Given this list of marker genes GLE1 (NCBI Gene Id 8012), ZC3H11A, FBL, TCP1, IGF2BP2, NUP37, IGF2BP1, NUP43, KPNB1, DHX9, ARC, AAAS, FXR1, RTRAF, YTHDC1, TPR, NSUN2, EXOSC10, DDX39A, THOC3, NUP93, NXF5, IWS1, ZNHIT3, SARNP, DKC1, EIF4A3, QKI, MEX3D, NUP50, NOL6, NUP188, A1CF, MVP, FMR1 (fragile X messenger ribonucleoprotein 1), NUP205, RAN, SMG5 (SMG5 nonsense mediated mRNA decay factor), HSF1, NXT2, FXR2, PCID2, SRSF1, ALKBH5 (alkB homolog 5, RNA demethylase), NXF1, YBX1, NUP160, HNRNPA1L2, RAE1, EIF4E, DDX19B, CCT5, SETD2, FUBP3, G3BP2 (G3BP stress granule assembly factor 2), PARN, ZFP36L1, PARP11, POM121B, C12orf50, NUP107, NUP62, MRPL18, NAF1, SUPT6H, NUP214, ZFP36 (ZFP36 ring finger protein), NUP88, THOC6, MX2, NCBP1, SLBP, KIF5C, UPF2 (NCBI Gene Id 26019), WRAP53, NPIPA1, POM121, PIH1D1, LRPPRC, PUM2, NXF2, LUZP4, NDC1, PRPF6, NUP42, CCT2, NUTF2, SHQ1, UPF3B, ATR, CETN2, SRSF3, YY1, TERF1, DDX19A, TOMM20, XPO1, CCT6A, ZC3H11B, FLOT1, CKAP5, SSB, SRSF7, NXF3, PNPT1, DDX25, NCBP3, NUP155, RUVBL1, AKAP8L, NPAP1, RBM15B, IGF2BP3, RANBP17, XPO5, DCP2, CCT8, CPSF6, ATXN2 (NCBI Gene Id 8095), POM121L2, PRPF31, THOC7, NRDE2, ENY2, ZNHIT6, HNRNPU, SEH1L, NXF2B, NOP58, THOC2, MCM3AP (minichromosome maintenance complex component 3 associated protein), NCBP2, RANBP2, RFTN2, PHAX, ZC3H11C, NUP35, SEM1, HNRNPA1, NUP133, RBFOX1, AGFG1, KHSRP, SIDT1, BICD2, HNRNPAB, DHX36, SMG7, THOC5, MAGOHB, FYTTD1, POLDIP3, STAU2, ATM, RUVBL2, TGFBR2, XPOT, TST, PEG10, WNK1, TOMM20L, NOP10, CHTOP (NCBI Gene Id 91678), NUP153, NUP210 (NCBI Gene Id 79985), HNRNPA2B1, ALYREF, CCT7, UPF1, SMG6 (SMG6 nonsense mediated mRNA decay factor), NUP58, AHCTF1, SENP2, KHDRBS1, HHEX, RBM8A, SNUPN, NUP98, SEC13, UPF3A, CAPRIN1, POM121C, SMG1, NXT1, BICD1, RFTN1, STAU1, PABPN1, NEAT1, RBM33, CCT4, NHP2, MAGOH, ZC3H3, TNKS, NUP85 (nucleoporin 85), NUP54, DDX39B (NCBI Gene Id 7919), ZNF385A, CETN3, SIDT2, CASC3, CCT3, THOC1, here is a description of the gene set: species: Homo sapiens A process in which RNA is transported to, or maintained in, a specific location. Human Gene Set: GOBP_RNA_LOCALIZATION